Given this list of marker genes TMBIM1, CASP8AP2, MIR23A, FAS, MIR27A, SP100, FAF1, ZDHHC7, SMAD5, here is a description of the gene set: species: Homo sapiens Human Gene Set: GOBP_FAS_SIGNALING_PATHWAY The series of molecular signals initiated by the binding of a ligand to a Fas receptor on the surface of the cell, and ending with the regulation of a downstream cellular process, e.g. transcription. Fas is a death domain-containing member of the tumor necrosis factor receptor (TNFR) superfamily.